Given this list of marker genes TRRAP, TPMT, NT5C3A, RIOX1 (NCBI Gene Id 79697), MGMT, FKBP5, CENPB, PATZ1, ARL2BP, GCAT (glycine C-acetyltransferase), INPP5F, MAP4K4, ESR2, TLE4, MYBBP1A, here is a description of the gene set: studied in species Homo sapiens Two cytidine analogues, gemcitabine (dFdC) and 1-beta-d-arabinofuranosylcytosine (AraC), show significant therapeutic effect in a variety of cancers. However, response to these drugs varies widely. Evidence from tumor biopsy samples shows that expression levels for genes involved in the cytidine transport, metabolism, and bioactivation pathway contribute to this variation in response. In the present study, we set out to test the hypothesis that variation in gene expression both within and outside of this pathway might influence sensitivity to gemcitabine and AraC. Specifically, Affymetrix U133 Plus 2.0 GeneChip and cytotoxicity assays were performed to obtain basal mRNA expression and IC(50) values for both drugs in 197 ethnically defined Human Variation Panel lymphoblastoid cell lines. Genes with a high degree of association with IC(50) values were involved mainly in cell death, cancer, cell cycle, and nucleic acid metabolism pathways. We validated selected significant genes by performing real-time quantitative reverse transcription-PCR and selected two representative candidates, NT5C3 (within the pathway) and FKBP5 (outside of the pathway), for functional validation. Those studies showed that down-regulation of NT5C3 and FKBP5 altered tumor cell sensitivity to both drugs. Our results suggest that cell-based model system studies, when combined with complementary functional characterization, may help to identify biomarkers for response to chemotherapy with these cytidine analogues. from publication Li L, Fridley B, Kalari K, Jenkins G, Batzler A, Safgren S, Hildebrandt M, Ames M, Schaid D, Wang L (PMID 18757419) Human Gene Set: LI_CYTIDINE_ANALOGS_CYCTOTOXICITY Genes whose expression in a panel of lymphoblastoid cell lines was associated with cytotoxicity of the anti-cancer analogs of cytidine, gemcitabine and cytarabine.